The following is a description of a gene set: studied in species Mus musculus Mouse Gene Set: GOBP_PARAMESONEPHRIC_DUCT_DEVELOPMENT The process whose specific outcome is the progression of the paramesonephric duct over time, from its formation to the mature structure. Mullerian ducts (or paramesonephric ducts) are paired ducts of the embryo that run down the lateral sides of the urogenital ridge and terminate at the mullerian eminence in the primitive urogenital sinus. In the female, they will develop to form the fallopian tubes, uterus, cervix, and the upper portion of the vagina; in the male, they are lost. These ducts are made of tissue of mesodermal origin., and this is the list of marker genes: Stra6, Lhx1, Greb1l, Wnt4, Pax2